Given this list of marker genes BACE2, TMEM176A, DTNA, TCEAL2, TMEM176B, ENSG00000238142, CLIC6, LARP6, RAI2, RNF32, RUNDC3B, WWC2, BEND7, CDYL2, FAM171A1, RMST, CST3, AGAP1, CLGN, DSG2, FGFR3, SLC22A17, LRP12, TEAD1, PALLD, MAGI1, DSEL, MITF, CLEC11A, ZNF521, FZD2, BEX3, SNTG2-AS1 (SNTG2 antisense RNA 1), SPRY2, PPM1H (protein phosphatase, Mg2+/Mn2+ dependent 1H), VWA5A, SERPINE2, PCSK5, JAM3, MYO10, NAP1L3 (NCBI Gene Id 4675), MARK1, NRIP1, NSD2, TRIM58, ZNF503, MYRIP, FZD8, KLHL13, PBX1, here is a description of the gene set: To better define the molecular basis of multiple myeloma (MM), we performed unsupervised hierarchic clustering of mRNA expression profiles in CD138-enriched plasma cells from 414 newly diagnosed patients who went on to receive high-dose therapy and tandem stem cell transplants. Seven disease subtypes were validated that were strongly influenced by known genetic lesions, such as c-MAF- and MAFB-, CCND1- and CCND3-, and MMSET-activating translocations and hyperdiploidy. Indicative of the deregulation of common pathways by gene orthologs, common gene signatures were observed in cases with c-MAF and MAFB activation and CCND1 and CCND3 activation, the latter consisting of 2 subgroups, one characterized by expression of the early B-cell markers CD20 and PAX5. A low incidence of focal bone disease distinguished one and increased expression of proliferation-associated genes of another novel subgroup. Comprising varying fractions of each of the other 6 subgroups, the proliferation subgroup dominated at relapse, suggesting that this signature is linked to disease progression. Proliferation and MMSET-spike groups were characterized by significant overexpression of genes mapping to chromosome 1q, and both exhibited a poor prognosis relative to the other groups. A subset of cases with a predominating myeloid gene expression signature, excluded from the profiling analyses, had more favorable baseline characteristics and superior prognosis to those lacking this signature. Top 50 up-regulated genes in cluster MS of multiple myeloma samples with characteristic expression spike of WHSC1. Human Gene Set: ZHAN_MULTIPLE_MYELOMA_MS_UP from publication Zhan F, Huang Y, Colla S, Stewart JP, Hanamura I, Gupta S, Epstein J, Yaccoby S, Sawyer J, Burington B, Anaissie E, Hollmig K, Pineda-Roman M, Tricot G, van Rhee F, Walker R, Zangari M, Crowley J, Barlogie B, Shaughnessy JD Jr (PMID 16728703) studied in species Homo sapiens